The following is a description of a gene set: studied in species Mus musculus Mouse Gene Set: GOBP_DENSE_CORE_GRANULE_EXOCYTOSIS The secretion of molecules (e.g. neuropeptides, insulin-related peptides or neuromodulators such as serotonin and dopamine) contained within a membrane-bounced dense core granule by fusion of the granule with the plasma membrane of a cell in response to increased cytosolic calcium levels., and this is the list of marker genes: Unc13c, Stxbp1, Rims1, Unc13b, Syt6, Rab3a (RAB3A, member RAS oncogene family), Syt4, Unc13d, Cadps2, P2rx7, Baiap3, Stxbp3, Snap25, Unc13a, Syt10, Stxbp2, Cadps